The following is a description of a gene set: Reactome Pathway: Regulation of signaling by CBL part of: Interleukin-3, Interleukin-5 and GM-CSF signaling This event has been computationally inferred from an event that has been demonstrated in another species.<p>The inference is based on the homology mapping from PANTHER. Briefly, reactions for which all involved PhysicalEntities (in input, output and catalyst) have a mapped orthologue/paralogue (for complexes at least 75% of components must have a mapping) are inferred to the other species. species: Mus musculus electronically inferred by orthology from the curated human pathway, and this is the list of marker genes: Pik3r2, Crk, Vav1, Pik3cb, Yes1, Rps27a, Fyn, Cbl, Syk, Ubb, Grb2